Given this list of marker genes Lpar6, P2ry14, P2ry13, P2ry6, Lpar4, P2ry10, P2ry2, Gpr17, P2ry1, P2ry4, P2ry12, here is a description of the gene set: P2Y receptors Mouse Gene Set: REACTOME_P2Y_RECEPTORS studied in species Mus musculus